Given this list of marker genes RTP1, SNORA63E (NCBI Gene Id 109617007), EIF2B5, CHRD, ST6GAL1, RPL29P9, EIF4G1, EIF2B5-DT, RTP4 (NCBI Gene Id 64108), KNG1, MCCC1-AS1, CYP2AB1P (cytochrome P450 family 2 subfamily AB member 1, pseudogene), ETV5 (NCBI Gene Id 2119), SNORA81, LINC01839, NMRAL2P, SST, CRYGS, LPP-AS2, HTR3E-AS1, SNORA63D, MIR5588 (microRNA 5588), HTR3C2P, HTR3C, TBCCD1, RPSAP31, ADIPOQ-AS1, ABCC5 (ATP binding cassette subfamily C member 5), ENSG00000272970, EIF4A2, RNU6-1105P, RTP2, EIF2S2P2, EEF1AKMT4, MIR1248, BCL6, MASP1, VPS8, HTR3E, HTR3D, ENSG00000283175, MCF2L2P1, KLHL6-AS1, HRG-AS1, LINC01840, AP2M1, EPHB3, C3orf70, TEDDM3P, DVL3, LINC02069, MAGEF1, RPS3P3, EHHADH-AS1, GPS2P2, PET100P1, ABCC5-AS1, LPP, CLCN2, PRICKLE1P1, RFC4, BCL6-AS1, PSMD2, HRG, LINC02020, ALG3, LINC01991, ABCF3, RPL34P10, LINC02051, B3GNT5, LINC02054, DGKG, CAMK2N2, MIR548AQ, IGF2BP2, EEF1AKMT4-ECE2, EEF1A1P8 (eukaryotic translation elongation factor 1 alpha 1 pseudogene 8), HRGP2, YEATS2-AS1, PSMD10P2, RPL4P4, MIR1224, SNORD66, FAM131A, SNHG33 (small nucleolar RNA host gene 33), DNAJB11, IGF2BP2-AS1, KLHL24, EHHADH, THPO, FLJ42393, MAP6D1, ECE2, FETUB, TRA2B, RPL39L, TVP23CP3, MIR4448, VWA5B2, LINC02043, MAP3K13, ENSG00000286086, SENP2, ENSG00000239093, ETV5-AS1, PARL, LINC02052, KLHL6, SNORA63 (NCBI Gene Id 6043), HSP90AA5P, MCF2L2, TMEM41A, RNA5SP151, POLR2H, RPS20P14, ADIPOQ, SNORA4, LAMP3, HRGP1, YEATS2, ENSG00000198491 (novel transcript), AHSG, MCCC1, LINC02041, SNORA63B, SNORD2, LIPH, here is a description of the gene set: studied in species Homo sapiens Human Gene Set: chr3q27